The following is a description of a gene set: A kind of neoplasm of the liver that originates from immature liver precursor cells and macroscopically is composed of tissue resembling fetal or mature liver cells or bile ducts. Human Gene Set: HP_HEPATOBLASTOMA Hepatoblastoma species: Homo sapiens, and this is the list of marker genes: SLC37A4, SKIC3, DPF2, ARID2, SOX4, ARID1A, KCNQ1, SMARCE1, SMARCA4, ARID1B (NCBI Gene Id 645070), DLK1, GPC4 (glypican 4), APC, MEG3, PKHD1, SMARCB1, KCNQ1OT1, SMARCC2, IGF2, SOX11, RTL1, CDKN1C, GPC3, DZIP1L, SMARCD1, SETBP1 (NCBI Gene Id 284262), SKIC2